The following is a description of a gene set: Regulation of gene expression by Hypoxia-inducible Factor Human Gene Set: REACTOME_REGULATION_OF_GENE_EXPRESSION_BY_HYPOXIA_INDUCIBLE_FACTOR species: Homo sapiens, and this is the list of marker genes: CITED2, EPAS1, CREBBP, VEGFA, EP300, EPO, HIF3A, HIGD1A, HIF1A, ARNT, CA9